The following is a description of a gene set: Human Gene Set: LAKE_ADULT_KIDNEY_C28_INTERSTITIUM species: Homo sapiens from publication Lake BB, Chen S, Hoshi M, Plongthongkum N, Salamon D, Knoten A, Vijayan A, Venkatesh R, Kim EH, Gao D, Gaut J, Zhang K, Jain S (PMID 31249312), and this is the list of marker genes: NFIA, REV3L, MED13L, KIAA1217, LDB2, ARHGAP10, UBE2E2, TTC28, CCN1, PTEN, TNC, PDLIM5, RBMS1, RPLP1, C7, AKAP12, A2M, EBF1, FNDC3B, PRKCA, SLIT3, ITSN1, USP53, CACNA1C, DACH1, TPM1, ROCK2, COL4A4, NR2F2-AS1, ZEB2, FOXO3, STK3, AUTS2, IL6ST, MIR99AHG, RERG, LPP, UGGT2, SCMH1, TIMP3, KALRN, PLXDC2, CALD1, UTRN, EPS8, APBB2, SSBP2, TACC1, MEIS1 (NCBI Gene Id 4211), DST (dystonin), PALLD, LAMA2, INPP4B (inositol polyphosphate-4-phosphatase type II B), RBMS3, ITGA1, THSD4, ROCK1, SYNE1 (NCBI Gene Id 85448), RASAL2, SORBS1, PRKG1, SETBP1, VMP1, NAV2, AKT3, IGFBP7, DGKH, COL4A1, ZBTB16 (zinc finger and BTB domain containing 16), THBS1, DPYD, LINC-PINT, TCF12, SBF2, TMSB4X, LHFPL6, MGP, EXT1, MEIS2, DCN, UACA, CBLB, NEGR1, MAP3K5, COL4A2, TSHZ2